Given this list of marker genes MT-CO3, PFKM, LARGE1, POMT2, POMK, ALDOA, FKRP, DAG1, LPIN1, CRPPA, OBSCN, B4GAT1, DPYS, MT-CO1, SIL1, POMGNT2, POMGNT1 (protein O-linked mannose N-acetylglucosaminyltransferase 1 (beta 1,2-)), B3GALNT2, RXYLT1, TANGO2, POMT1, HSPG2, COL4A1, FKTN, ALDOB, TGFB1, here is a description of the gene set: An abnormal concentration of aldolase in the serum. Aldolase is an enzyme responsible for converting fructose 1,6-bisphosphate into the triose phosphates dihydroxyacetone phosphate and glyceraldehyde 3-phosphate. Human Gene Set: HP_ABNORMAL_CIRCULATING_ALDOLASE_CONCENTRATION studied in species Homo sapiens Abnormal circulating aldolase concentration